Given this list of marker genes Septin3, Adam10, Capn2, Psen2, Rnf216, Psen1, here is a description of the gene set: The chemical reactions and pathways resulting in the breakdown of a protein at a synapse. species: Mus musculus Mouse Gene Set: GOBP_PROTEIN_CATABOLIC_PROCESS_AT_SYNAPSE